Given this list of marker genes NRAS, CREB3L1, CYP27B1, B3GAT3, MBTPS2, ANO5, PYCR1, DKK1, STAT3, SERPINF1, POT1, SMS, GLE1, IRX5, NOTCH2, MOGS, TRPV6 (transient receptor potential cation channel subfamily V member 6), WRAP53, HS6ST1 (NCBI Gene Id 9394), SLC29A3, PARN, LIFR (LIF receptor subunit alpha), SPRY4, DKC1, MINPP1 (multiple inositol-polyphosphate phosphatase 1), MTAP, B3GALT6, NHP2, TERC (NCBI Gene Id 7012), CASR (NCBI Gene Id 846), ATP7A, ALPL, CYP2R1, TNFSF11, RUNX2, RTEL1, RRM2B, SLC34A1, CLCN7, PPIB, TINF2, SQSTM1, SEMA3A, CLTCL1 (NCBI Gene Id 8218), PROK2, PRDM5, LRP5, TMEM38B, COL11A1, VCP, IDH2, PTEN, CHST3, PROKR2, ZNF687, B4GALT7, USB1, SNX10, PHLDB1, NGF, SOX9, NOP10, GNAS, CTNND2, HESX1, PLEKHM1, P3H1, TCIRG1, TRIP11, ANTXR2, CBS, FOXE1, FGF17 (NCBI Gene Id 8822), CRTAP, ELP1, CCDC141, WDR11, YY1AP1, SP7, FGF8, MYH3, DUSP6, TYMS, SEC24D, TACR3, CLCN5, FLRT3, CHD7, TENT5A, NPM1, SGMS2, DCC, CA2, WNT3A, SEMA5A, TNFRSF11A (NCBI Gene Id 8792), IDH1, PDGFRB, UNC45A, KRAS, TERT, COPB2 (COPI coat complex subunit beta 2), NFIX, FZD4, CCDC134 (NCBI Gene Id 79879), ANOS1, HABP2, OCRL, SPARC, FKBP10 (FKBP prolyl isomerase 10), SLC34A3 (solute carrier family 34 member 3), CHD6, GORAB, LBR, FEZF1, NDNF, VDR, TBCD, BMP1, COL1A2, KDELR2, PLOD2, COL1A1 (NCBI Gene Id 4970), CTC1, P4HB, SOX10, TNFRSF11B (NCBI Gene Id 4982), FGFR1, IFITM5, WNT1, IL17RD, SLC7A7, HRAS, here is a description of the gene set: The repeated occurrence of bone fractures (implying an abnormally increased tendency for fracture). species: Homo sapiens Recurrent fractures Human Gene Set: HP_RECURRENT_FRACTURES